Given this list of marker genes SEH1L, NPRL2, WDR24 (NCBI Gene Id 84219), DEPDC5, CASTOR2, NPRL3, SZT2, CASTOR1, MIOS, WDR59, RRAGA, SESN3, SESN1, SEC13, here is a description of the gene set: A GTPase-activating protein (GAP) complex that regulates TORC1 signaling by interacting with the Rag GTPase. In S. cerevisiae the complex contains Seh1p, Sec13p, Npr2p, Npr3p, Iml1p, Mtc5p, Rtc1p, and Sea4p. species: Homo sapiens Human Gene Set: GOCC_SEH1_ASSOCIATED_COMPLEX